Given this list of marker genes CORO1A, PTPN9, DOCK2, MYBL2 (NCBI Gene Id 4605), TNFRSF10A, LONP1, FBXO5, LRRCC1 (leucine rich repeat and coiled-coil centrosomal protein 1), CCNB1, XRCC1, ATF6, CDC25C, AK3, CDKN1C, LPAR2, ZBTB33, TACC3, SETDB2, ALKBH5, SULT1A3, CCNE1, MRGPRX4, PDCD6IP, MAZ, UBR7, NDUFB7, PHKA2, SH3BP1, PRPF38A, SNAPC5, TASL, PARP16, GTF2F2, SKIC8, POLR2K, UCK2, TAFAZZIN, FANCG, BIRC5, NFRKB, FOXM1, LGALS1, KDM5C, MST1, DNMT1, PIR, TBC1D14, MXI1, LIPA, ATP8B3, TTC14, MAP2K5, NCAPH, MED29, DEPDC1, INTS7, ZNF267, TRAK1, BST1, GFI1, SEL1L, CDK6, HOXA7, SMARCA2, FCGRT, MIB1, TBRG4, E2F1, CDK4, COPS2, HERC2, here is a description of the gene set: Pol II transcription. studied in species Homo sapiens Human Gene Set: MODULE_308